The following is a description of a gene set: Any nuclear DNA replication that is involved in a mitotic cell cycle. Human Gene Set: GOBP_MITOTIC_DNA_REPLICATION studied in species Homo sapiens, and this is the list of marker genes: BRCA2, MCM4, RECQL5, CDC45, LIG1, GINS3, BCL6, RAD51, GINS1, ZMPSTE24, FGFR1, MCM2, MCM6, MCM3, POLA1, RTF2, TK1